The following is a description of a gene set: Human Gene Set: HP_AORTIC_VALVE_CALCIFICATION species: Homo sapiens Deposition of calcium salts in the aortic valve. Aortic valve calcification, and this is the list of marker genes: LMNA, NOTCH1, RIGI, SMAD6, GBA1, IFIH1, GATA5, NKX2-5, HGD, ZMPSTE24